The following is a description of a gene set: species: Mus musculus Mouse Gene Set: GOCC_JUNCTIONAL_MEMBRANE_COMPLEX Complex formed in muscle cells between the membrane of the sarcoplasmic reticulum and invaginations of the plasma membrane (T-tubules)., and this is the list of marker genes: Casq2, Ryr3, Jph2, Bag5, Jph3, Trdn, Ryr1, Jph1, Jph4